The following is a description of a gene set: Catalysis of the hydrolysis of ester linkages within a single-stranded deoxyribonucleic acid molecule by creating internal breaks. studied in species Homo sapiens Human Gene Set: GOMF_SINGLE_STRANDED_DNA_ENDODEOXYRIBONUCLEASE_ACTIVITY, and this is the list of marker genes: ERCC1, XRCC1, MRE11, ENDOG, SETMAR, DCLRE1C, ASTE1, EXOG, ERCC4, RAD50, RBBP8